The following is a description of a gene set: Human Gene Set: HFH3_01 Genes having at least one occurrence of the motif KNNTRTTTRTTTA in the regions spanning 4 kb centered on their transcription starting sites. This matches the FOXI1 transcription factor binding site V$HFH3_01 (v7.4 TRANSFAC). studied in species Homo sapiens, and this is the list of marker genes: TWIST1, TYRO3, CHD6, TMEM209, EPN1 (epsin 1), KAT6B, UBAP2L, NEUROD2, IRS4, PLAG1, SLIT3, BUB3, CDH10, PHTF2, ELAVL4, COLEC10, SLC39A8, GRB7, NIN, BPIFA3, RAB3IP, NMNAT2, CIMIP6, INMT, HOXA11, UBXN10, GNAO1, NFIA, NKD1, UBR1, SCUBE3 (signal peptide, CUB domain and EGF like domain containing 3), NEDD4, GOLGA1, ID1, CELF4, HOXC4, MYL1, GPRC5C, MAP2K5, NR4A3, CRH, MEF2C, NCAM1, SOX15, FOXP2, REST, SYT6, PAIP2, TNF, QRICH1, KCTD15, TLE3, IFNA17, TCF7L2, TJP1, MID1, KLF12, RBP3, CSNK1E, MIDEAS, ATP2A2, FBXO11, FUT8, SCML1, FOXD3, ETV5, CCDC85B, CNBP, TSHZ2, NSG2, PNPLA6, AHI1, SGK1, BMP5, SLC35C2, SHOX2, C1orf43, IFNA8, PRKAG1, ID2, IQGAP2, LINC00314, GFRA1, CTDSPL2, HOXB8, DOCK3, GRIK2, CAB39L, PIK3C2A, ORC4, DUSP1, ITGA3, FLI1, PNMA1, BCL11B, WNT5A (Wnt family member 5A, NCBI Gene Id 7474), RUNX2, HTR1B, CDC42EP3, UBE2H, CEBPA (NCBI Gene Id 1050), CYP26B1, TSPAN17, NIPBL, C12orf57, C1QTNF3, CPNE1, CLDN8, TOB1, SLC10A7, MCC, ADGRB3, CADM2, RAD21, REPS2, NR3C2 (NCBI Gene Id 4306), RGS22, REEP4, EGR2, KLF7, PALMD, ZMYND8, PPP1CB, GAL3ST4, SLITRK2, COL13A1, CDAN1, NAV3, FOXJ3, FBXW11, ADAM23, VGLL3, RFTN2, RTL9, CPEB4, CEBPA-DT, SLITRK6, LGI1, SYNRG, CILK1, ARTN, NECTIN1, CCN1, DUSP21, VASN, CRIM1 (cysteine rich transmembrane BMP regulator 1), TWIST2 (twist family bHLH transcription factor 2), RGMA, FBXL22, MAF, BRIP1, SCG3, DMD, NIM1K (NCBI Gene Id 167359), PRRC2A, TBX4, HOXA10, ADAMTS14 (ADAM metallopeptidase with thrombospondin type 1 motif 14), RPS6KB1, HOXB3, OMD, PARP8, SIX5, ZBTB37, ETV1, ASIC2, SCAMP1, IGSF9B, SMARCA2, WDR44, RBP2, OTX2, SLC44A1, CHCHD7, ATXN7L1, ARHGAP30, PRDM1, ZHX2, LHX3, NOVA1, IFNA10, DLG2, MSI2, ATP1B4, GABRE, GPR142, PRR34, PCDH17, LTA, SSH3, STOML2, KRTAP17-1, GRM3, HESX1, TNFSF15, PRX (NCBI Gene Id 57716)